Given this list of marker genes Hnf1b, Six1, Gata3, Six4, Gdnf, here is a description of the gene set: Any process that modulates the rate, frequency or extent of mesonephros development. Mesonephros development is the process whose specific outcome is the progression of the mesonephros over time, from its formation to the mature structure. The mesonephros is an endocrine and metabolic organ that filters the blood and excretes the end products of body metabolism in the form of urine. studied in species Mus musculus Mouse Gene Set: GOBP_REGULATION_OF_MESONEPHROS_DEVELOPMENT